Given this list of marker genes Mapk11, Ppp2r5d, Rps27a, Rela, Peli2 (NCBI Gene Id 93834), Nfkb2, Fos, Ikbkb (inhibitor of kappaB kinase beta), Hmgb1, Rps6ka5, Map2k7, Jun, Tab1, Nfkb1, Ube2v1, Ube2n, Tab3 (TGF-beta activated kinase 1/MAP3K7 binding protein 3), S100b, Nfkbib, Vrk3, Casp8, Cul1, Lrrc14, Ubb, Irak1, Nfkbia, Nkiras1, Map2k6, Tifa, Nlrx1, Mapk3, Ecsit, Map2k4, Map3k8, Tab2, Map2k3, Mapk9, Ppp2r1b, Mapk7, Dusp6, Nlrc5, Dusp7, Ager, Mapk8, Mapk14, here is a description of the gene set: Reactome Pathway: MyD88 cascade initiated on plasma membrane electronically inferred by orthology from the curated human pathway part of: Toll Like Receptor 10 (TLR10) Cascade; Toll Like Receptor 5 (TLR5) Cascade This event has been computationally inferred from an event that has been demonstrated in another species.<p>The inference is based on the homology mapping from PANTHER. Briefly, reactions for which all involved PhysicalEntities (in input, output and catalyst) have a mapped orthologue/paralogue (for complexes at least 75% of components must have a mapping) are inferred to the other species. species: Mus musculus